Given this list of marker genes BRCA1, NHEJ1, ATP23, XRCC5, XRCC4, FANCD2, LIG4, PRKDC, XRCC6, PALB2, TP53BP1, FANCI, PAXX, ASCC1, DCLRE1C, ATM, RCOR1, CYREN, BRCA2, KDM1A, PHF21A, ASCC2, ASCC3, here is a description of the gene set: A protein complex involved in DNA repair processes including direct reversal, base excision repair, nucleotide excision repair, photoreactivation, bypass, double-strand break repair pathway, and mismatch repair pathway. studied in species Homo sapiens Human Gene Set: GOCC_DNA_REPAIR_COMPLEX